Given this list of marker genes SAMD9, COL4A6, GMPPA, PHOX2B, COL4A5, TRAPPC11, MYH11, MEIS2, IARS2, MYO1H, FLVCR1, IVNS1ABP, STAT3, ACTB, GLA, MRAP, AAAS, GUCY1A1, here is a description of the gene set: Human Gene Set: HP_INEFFECTIVE_ESOPHAGEAL_PERISTALSIS Reduced or inadequate esophageal peristalsis, with resultant slow passage of contents through the esophagus. Ineffective esophageal peristalsis species: Homo sapiens